The following is a description of a gene set: studied in species Homo sapiens The subcomplex of the proteasome regulatory particle that forms the peripheral lid, which is added on top of the base subcomplex. Human Gene Set: GOCC_PROTEASOME_REGULATORY_PARTICLE_LID_SUBCOMPLEX, and this is the list of marker genes: ADRM1, PSMD13, SEM1, PSMD11, PSMD12, PSMD3, PSMD14, PSMD8